The following is a description of a gene set: species: Mus musculus Mouse Gene Set: GOBP_REGULATION_OF_PROGRAMMED_CELL_DEATH Any process that modulates the frequency, rate or extent of programmed cell death, cell death resulting from activation of endogenous cellular processes., and this is the list of marker genes: Angpt1, Mertk, Wnt11, Mir20a, Myo18a, Serpinb9e, Nr1h4, Sptlc1, Tex11, Slc46a2, Hrk, Krit1, Ep400, Zeb2, Hells, Tnfaip8l2, Sox4, Zfp36 (NCBI Gene Id 22695), Dnajc5, Utp11, Prkdc, Pparg, Hdac2, Gsk3a, Slk, Cfdp1, Ccnd2, Thoc1, Brd8, Il2, Pla2g1b, Abraxas2, Comp, Ltk, Gcg, Mir25, Cdkn1b, Tbx3, Lyn, Csf2, Efhc1, Unc5c, Pdpk1, Zbp1, Id3, Hspb1, Folh1, Hdac3, Ptprc, Fis1, Mir92-1, Bcl2a1d (B cell leukemia/lymphoma 2 related protein A1d), Plk3, Mir293, Naa35, Adam17, Cdk11b, Lcn2, Prkch, Akt1, Plk1, Mir295, Pcgf2, Pcid2, Avp, Mad2l1, Sarm1, Epc1, Itch, Mrgbp, Selplg, Rrm2b, Dedd, Cdsn, Mir106a, Supv3l1 (NCBI Gene Id 338359), Ago4, Ltb, Sh3glb1, Lrp5, Tnfrsf12a, Ell3, Mir92-2, Adora1, Psme3, Ndnf, Pim2, Rad21, Eif2b5, Acaa2, Dhodh, Psmg2, Dad1, Bcl3, Son, Gbe1, Pdcd10, Hnrnpk, Rarg, Klhl20, Vnn1, Foxp1, Mdm4, Ppara, Ufm1, Nog, Xrcc2, Foxa1, Ccl12, Draxin, Prdx2, Smad3, Wnt4, Fgfr1, Traf1, Prkca, Zmat3, Tfap2a, Spry1, Mir294, Ube2z, Moap1, Hdac4, Hyou1, Tsc22d1, Nos3, Card14, Cdkn2d, Akt1s1, Pla2r1, Stat1, Epc2, Cxcl10 (NCBI Gene Id 15945), Dlc1, Mien1, Bace1, Ifnb1, Slc25a31, Ctsh, Nr3c1, Mtch1, Mtch2, Mtrnr2l7, Tnfaip8l3, Hsp90ab1, Rps6kb1, Map3k11, Ilk, Lgals1, Egln1, Pawr, Bid, Pip5kl1, Ctsd, Foxc2, Dll1, Grik5, Cbs, Itpr1, Phlda1, Tgfb1, Fosl1, Itga4, Bmpr1a, Hnf1b, Zbtb16, Styxl1, Pax2, Ctrb1, Gstp2, Tgm2, H2-M3, Icam1, Gas6, G6pdx, Tnfrsf1b, Fxn, Atf2, Rack1, Fnip1, Nkx2-6, Lypd3, Ambra1, Siglec1, Nck2, Pgr, Rnf31, Prkcd, Rybp, Prdx3, Cldn7, Gdnf, Nme5 (NME/NM23 family member 5), Snca, Grn, Mael, Diablo, Il2rb, Cdk4, Ier3ip1, Casp6, Pten, Kif14, Atm, Hsh2d, Igf2r, Vegfa, Ung, Cd44, Trim2, Slc1a1, Rhob, Csf1r, Dab2ip, Cpeb4, Oog1, Acsl5, Ddx42 (NCBI Gene Id 78522), Trp53, Nmnat1, Rapgef3, Cflar, Traf3, Plac8 (placenta-specific 8), Rps7, Pcdhgc4 (NCBI Gene Id 93707), Sh3rf1, Maged1, Ptgfr, Hsp90aa1, Casp14, Slc25a4, Kit, Syce3 (NCBI Gene Id 75459), Creb3l1, Sphk2, Adcy10, Zfp830, Grina, Prf1, Pla2g3, Ptprf, Itgav, Adam8, Ptma, Arf4, Hpgd, Degs1, Birc5, Il12a, Plk5, Serpinb9, Bbs10, Twist1, Bag1, Lep, Fyn, Trp53inp1, Cntf, Bdkrb2, Nes (nestin), Cd248, Tnf, Rxra, Phip, Sgk3, Hyal2, Atg5, Alkbh1, Daxx, Thap11, Msx2, Qrich1, Esr1, Foxe3, Ppp1r15a, Tlr3, Bbc3, Hmga2, Net1, Tnfaip3, Rock1, Tcim, Ikzf3, Edn1, Fabp1, Irak2, Nos2, Irf1, Mpv17l, Ghrl, Pcmt1, Rarb, Prok2, Eef1e1 (eukaryotic translation elongation factor 1 epsilon 1), Irak3, Abl1, Nfkbid, Tnfaip8l1, Fcer2a, Map3k5, Mybbp1a, Fbxo32, Nppc, Lox, Bnip3, Cd3g, Trim32, Fgf20, Mnt, Lcmt1, Yap1, Zfas1 (zinc finger, NFX1-type containing 1, antisense RNA 1), Atp6v0c, Nckap1l, Tctn3, Fzd1, Stxbp1, Sqstm1, Nol3, Slc2a3, Rnf157, Nqo2, Pidd1, Tox3, Caap1, Mllt11, Nrp1, Sp110, Rassf6 (NCBI Gene Id 73246), Pim3, Lzts2, Ptpa, Ar, Melk, Ccnd1, Siah1b (NCBI Gene Id 20438), Wwox, En2 (NCBI Gene Id 13799), Eif5a, Evi2b, Gata4, Pttg1ip (pituitary tumor-transforming 1 interacting protein), Gstp3, Bak1, Slc9a1, Cx3cr1, Actn4, Tcf7l2, Apip (NCBI Gene Id 56369), Stk17b, Npm1, Ang, Nqo1, Atg7, Bnip3l, Jak3, Bcl2l2, Map3k10, Slc27a4, Bcl2a1c, Akr1b1, Psmd10, Rpl26, Acvr1, Arg1, Wnt5a, Clip3, Kdm1a, Fgf10, Cblb, Hoxa13, Mmp9, Agap2, Srpk2, Dnajc3, Sod2, Hypk, Sox9, Sod1, Pycr1 (NCBI Gene Id 209027), Asic2, Prkd2 (protein kinase D2), Msx1, Mecom, Ywhaz, Nfix, Cdk19, Plaur, Psen1, Bad, Sfrp4, Cers6, Capn3, Map2k6, Irf8, Cyld, Gas1, Ager, Pth, Chek2, Snai2, St3gal1, Eef2k, Htr2b, Ccn1, Ankrd13c, Drd3, Dapk3 (death-associated protein kinase 3), Eif2a, Serpinb9d (NCBI Gene Id 20726), Traf6 (NCBI Gene Id 99098), Bmpr1b, Shh, Unc13b, Irf3, Scp2, Taf6, Tyro3, Ntf3, Zpr1, Cep63, C6, Stk3, Aldh1a1, Ghrh, Ripk2, Cd160, Stk26, Trpm7, Akap12, Ntrk2, Prmt2, Ace, Camk2a, Maz (NCBI Gene Id 17188), Rps3a1, Pou3f3, Oma1, Alms1 (NCBI Gene Id 381791), Cxcr2 (NCBI Gene Id 12765), Naa15, Parp1, Syngap1, Hpn, Smad5, Ube2m, Lig4, Klrk1, Naip5, Bdnf, Psen2, Insl3, Sncb, Aldh1a2, Actb (actin, beta), Map2k4, Uri1, Clu, Bmyc, Brca1, Ubd, Kcnh8, Ngb, Spdef, Fgfr2, Usp42, Sap18b, Noc2l, Eya2, Isl1, Gdf5, Mif, Fgf21, Sap18 (Sin3-associated polypeptide 18), Cd40lg, Wt1, Mir106b, Yeats4, Xiap, Cerkl, Tnfsf14, Cdkn2a, Taf9, Gli3, Nop53, Pramel1, Gsk3b, Tbx1, Rbm25 (NCBI Gene Id 70221), Igfbp3, Gstp1, Gstp-ps, Fam162a, Tmbim6, Stradb, Ltbr, Tnfrsf8, Tmem109, Dnm1l, Vhl, Golph3, Myocd, Aars1, Bcl6, Wdr35, Traf4, Ing1, Bhlhb9, Ppp1r13b, Il18 (interleukin 18), Pam16, Adcyap1 (adenylate cyclase activating polypeptide 1), Ccar2, Il20ra, Tnfrsf23, Creb3, Khdrbs1, Il6st, Pip, Cdk5, Malt1, Il19, Usp17le, Map2k5, Kras, Capn10, Adm (adrenomedullin), Nat8f1, Katnb1 (katanin p80 (WD40-containing) subunit B 1), Srpx (sushi-repeat-containing protein), Spp1, Hmgcr, Ccl19, Tomm70a, Sp100, Birc3, Zfp622, Tbx20, Gpx1, Slc35f6, Armc10, Prkcq, Fth1, Adprs, Pin1, Sycp2, Cradd, Dapk2, Map2k1, Oog3, Wnt16, Runx3, Mir19b-2, Acvr1c, Lifr, Apaf1, Hif1a, Map3k20, Carm1, Nlrc4, Cited2, Kitl, Gapdh, Phb1 (prohibitin 1), Rsl1d1, Id1 (NCBI Gene Id 98917), Gnaq, Notch1, Cat, P4hb, Nfatc3, Tfpt, Ywhah, Fndc1 (NCBI Gene Id 68807), Grid2, Ptpn2, Grem1, Gria4, Txnrd1, Rela, Bcl2l10, Hrg, Lrp6, Ppt1, Zbtb7a (zinc finger and BTB domain containing 7a), Traf7, Ubb, Klf4, Cxcr3, Ackr3, Foxc1, Ets1, Itgb1, Gsn, Blvra, Ahr, Ido1, Inca1, Card9, Madd, Bcl2l15, Ppp2r1a, Endog, Dock8, Arrb2, Mydgf, Ing2, Bcl2l13, Ccl21e (NCBI Gene Id 100504239), Knl1, Dicer1, Pmp22, Mapk9, Fga, Ppp5c, Fbxo10, Mtor, Tspo, Gadd45b, Pdx1, Ing4, Akt2, Mdk, Mutyh, Myb, Qki, Bard1, Plxnd1, Prop1, Fn1, Sphk1, Ptrh2, Erbb3, Aatf, Flt4, Sfpq, Hsp90b1, Lta, Babam2 (BRISC and BRCA1 A complex member 2), Traf2, Tmbim1, Nae1 (NCBI Gene Id 260355), Foxb1, Stat5b, Steap3, Rps3, Prr7, Ppargc1a (NCBI Gene Id 320239), Stub1, Dedd2 (NCBI Gene Id 67379), Syvn1, Ctns, Nox4 (NCBI Gene Id 50490), Fank1, Agtr1a, Myc, Tardbp, Higd2a, Slc39a10, Kank2, Tomm22, Park7, Ccng1, Ccl19-ps4, Atf6, Nr4a3, Trim35 (tripartite motif-containing 35), G2e3, Sik1, Dcun1d3, Flna, Rbm5, Spink2, Cx3cl1, Txndc12, Aifm2, Kat5, Usp15, Ptpmt1, Adrb1, Pou4f1, Fhl2, Lef1, Aimp2, Ccl19-ps6, Slc25a5, Shc1, Xpnpep1, Kdm2b, Ivns1abp, Hipk2, Eno1, Fbh1, Mapk8ip3 (mitogen-activated protein kinase 8 interacting protein 3), Fkbp8, Ptprz1, Rb1, Pde5a (phosphodiesterase 5A, cGMP-specific), Aurkb, Epcam, Apbb3, Mir124a-1, Hspb2, Prlr, Aipl1, Ankrd1, Thbs1, Vps54, Slc7a5, Por, Tnfsf4, Ormdl3, Dstyk, Bnip3l-ps, Gadd45a, Bmp2, Syk, Cblc, Igf1, Mir20b, D1Pas1, Crlf1, Sfrp1, Pdcd4, Gja1, Asah2, Fas, Ccar1, Trim39, Phlda2, Tgfbr1, Htra4, Hras, Pak2, Hk3, Bax, Itgb3, Krt18 (NCBI Gene Id 16668), G0s2, Gata2, Cck, Opn3, F2r, Wdr73, Cdc34 (NCBI Gene Id 216150), Cd27, Cd38, Hmgn5, Cd2ap, Usp17lc, Gramd4, Ntsr1, Stil (NCBI Gene Id 230631), Rgl2 (ral guanine nucleotide dissociation stimulator-like 2, NCBI Gene Id 19732), Naa38, Taf9b, Tfrc, Alx3, Sirt5, Birc7, Prodh, Dnaja3, Ucn, Nf1, Gimap8, Ncf2, Fbxo7, Atf4, Egln3, Npc1, Ddx20, Ptpn5, Ddrgk1, Ngf, Trrap, Sox8, Dpep1, Retreg1, Trap1, Cln3, Flcn, Rps6ka2, Adamts20, Mapk7, Il7, Foxq1, Trpv1, Fzd3, C1qbp, Usp36, Kcnj1, Ciapin1, Ppard, Pxt1, Map3k7, Cd59a, Tex261 (NCBI Gene Id 68003), Ing3, Nkx2-5, Gimap5, Clec7a, Ruvbl1, Epha7, Dipk2a, Ccn2, Mybl2, Lgmn, Nrbp2, Tmem161a, Tnfrsf18 (NCBI Gene Id 21936), Nr4a2, Fbxw7, Tnfsf11, Igf1r, Fbxo11, Ptpn1, C5ar1, Serpinb9f, Cidea, Braf, Agtr1b, Erbb4, Inhba, Ctnnbl1, Lrp1, Dlg5, Tfap4, Rnf34, Ednra, Casp2, Hcar2, Faim, Lhx3 (NCBI Gene Id 16871), Fnta, Proc, Thra, Mir17, Pcdhgc5, Niban2, Anxa1, Hhip, Ctsc, Nme2, Musk, Pdcd2, Skp2, Casp3, Ndufs3, Stat5a, Foxl2, Morf4l2 (NCBI Gene Id 71961), Slc7a11, Nlrp1a, Tpd52l1, Itsn1, Tent5b, Triap1, Tslp, Bcl2, Ncl, Efna1, Nfatc4, Htatip2, Eya4, Il10, Stx4a, Tomm40, Npy5r, Ednrb, Hspa9, Mcl1, Apoe, Hdgf, Raf1, Dmap1, Fgf2, Cdk5r1, Nupr1, Mbtd1, Agtr2, Slc40a1, Vdac2, Lrp2, Mir292, Dsg2, Trps1, Erp29, Smo, Mfn2, Itga5, Hspa5, Rbck1, Akr1c18, Gli2, Gata1, Dab2, Slc25a27, Trp73, Timp1, Serpinb13, Cyct, Hoxa5, Spry2, Ccl21f, Rps6ka3, Serpinb9c, Ptk2 (NCBI Gene Id 14083), Rapsn, Tmem215, Adam10, Star, Hsph1, Lmna, Cxcl1, Rgn, Rhoa, Mfsd8 (major facilitator superfamily domain containing 8), Tmbim4, Cideb, Tmigd1, Ccl21b, Bcl11b, Cul7, Kcnma1, Igbp1, Erfe, Map2k7, Cdc73, Laptm5, Prkaa1, Zfp385a, Dyrk3, Ankrd2, Hax1, S100b, Sirt4, Dusp6, Btg1, Gpam, Nrg1, Tnfrsf4, Ncoa1, Camk1d, Smad4, Bcl10, Cttn (NCBI Gene Id 68623), Pea15a, Bin1, Osm, Pax8, Egr3, Clec5a, Bhlhe23, Itm2c, Muc2, Cast, Egfr, Gnai2, Tle5 (TLE family member 5, transcriptional modulator), Sox2, Wnt10b, Ctnnb1, Tmem14a, Gnrh1, Ier3, Scx, Lims1, Zfand6, Tpt1, Stambp, Plk2, Hey2, Atox1, Prkaa2, Phlpp1, Txnip, Pramel7, P2rx7, Bclaf1, Sort1, Fgg, Tcf7, Actl6a, Pmaip1, Gapdhrt, Optn, Lhx4, Tifab, Ccl19-ps3, Rhbdd1, Mir93, Nod1, Gpld1, Mal, Tlr6, Gadd45g, Wnt1, Calhm2, Apbb1, Nat8b-ps, Med1, Qars1, Pla2g4a, Adipoq, E2f1, Hspb6, Dlx1, Tmem132a, Adrb2, Dpp9, Umodl1, Pepd, Pdgfrb, Crhr1, Frzb, Fadd, Asah1, Ngfr, Fgb, Angpt4, Muc4, B4galt1, Sgk1, Sra1, Pak3, Tgfbr3, Irs2, Hspa1b, Pin1rt1 (NCBI Gene Id 241593), Fgfr3, Lpar1 (lysophosphatidic acid receptor 1), Cd74, Ptk2b, Smarca4, Alpk2, Ankle2, Ctnna1, Rara, Dnaja1, Olfm1, Dkkl1, Kpna1, Map3k9, Birc2, Siah1a, Aif1, Plcg2, Il4, Ptgs2, Tfap2b (transcription factor AP-2 beta), Egln2, Cdkn1a, Phlda3, Nox1, Capn1, Nherf1, Pcp4, Serinc3, Tnfrsf1a, Tigar, Xrcc4, Hmgb2, Mlst8, Ube2b, Mtdh, Apc, Rnps1 (RNA binding protein with serine rich domain 1), Il1rn, Cdk1, Eif2ak2, Prkci, Nsmaf, Flt3l, Lims2, Prnp (prion protein), Nkx3-2, Muc1, Serbp1, Atad5, Hmox1, Grp, Rest, Neurl1a, Mt1, Adar, Sigmar1, Pnp, Naip6, Apbb2, Pdcd5, Plagl2 (NCBI Gene Id 99408), Itpkb, Gpx4, Pkhd1, Nuak2, Bok, Apex1 (apurinic/apyrimidinic endonuclease 1), Itga6, Mff, Snx6, Itga1, F2rl1, Slc39a7, Pdxk, Arg2, Mmp2, Araf, 4930453N24Rik, Msh2 (NCBI Gene Id 17685), Hgf, Pde1a, Il24, Rnf183, Jun, Ppp2r2b, Il7r, Scrib, Marchf7, Arhgap10, Dhrs2, Ccl5, Hnf1a, Mpz, Il12b, Card11, Opa1, Gch1, Tm7sf3, Fam72a, Bub1, Rps6, Arhgef7, Ift57, Six1 (NCBI Gene Id 20471), Aqp1, Ifit3b, Hipk3, Bcl2a1a, Cidec (NCBI Gene Id 14311), Chst11, Cdc34b (NCBI Gene Id 53980), Mycn, Bag6, Rps6-ps4, Bmp4, Pa2g4, Smpd1, Tjp1, Arl6ip1, Srsf6, Rnf122, Epo, Esr2, Spata2, Gcm2, Deptor, Ascl1, Nat8f7, Ecscr, Pdcd6, Htra1, Sema5a, Tia1, Hmgb1, Trip10, St8sia2, Ep300, Pou3f4, Trp53bp2 (NCBI Gene Id 98424), Zc3h12a, Nup62, Notch2, Dkk1, Vdac1, Dynapl1, Epha4, Rad9a, Sirt1, Wfs1, Lgals2, Tgfb3, Cdc42, Rybp-ps, Bcl2l1, Arnt2, Cabin1, Bag3, Ddias, Tmc8, Gimap3, Sin3a, Bag4, Cd274, Rb1cc1, Ihh, Dpp8, Lats1, Casp9, Ttpa, Pdia3, Prkcg, Ifit2, Cryaa, Gsdma3, Acin1, Smg9, Cyp1b1, Rbfox2, Kifap3, Rbm10 (RNA binding motif protein 10), Eef1a2, Btc, Il3, Pias1, Jak2, Cd59b, Sh3rf2, Fate1, Dspp, Csnk2a1, Col18a1, Itgb3bp (NCBI Gene Id 67733), Clcf1, Mpl, Zswim2, Tgfa, Casp12, Ints1, Mag, Cav1, Capn2, Sfrp2, Abl2, Grk2, Nos1, Glo1, Csrnp3, Mdga2 (NCBI Gene Id 320772), Ret, Palb2 (NCBI Gene Id 233826), Pomc, Stk4, Rasa1 (NCBI Gene Id 218397), Gba1, Mt3, Six4, Zfp36l1, Pdcd5-ps, Fasl, Ltf, Anp32a, Ccr5 (C-C motif chemokine receptor 5), Gfer, Hand2, Nacc2, Ramp2, Yme1l1, Eno1b, Fgf4, Rapgef2, Bik, Hk1, Ano6, Bcl2a1b, Cd40, Emilin2, Nf2, Ern1, Frs2 (fibroblast growth factor receptor substrate 2), Ldha, Ndufaf4, Emilin1 (elastin microfibril interfacer 1), Cacna1a, Siah2 (NCBI Gene Id 99497), Map4k4, Mrtfa, Cdh5, Htra2, Usp17la, Naip2, Bnc2, Plscr3, Usp47, Rnf7, Cryba1, Tgfb2, Angptl4, Ei24, Aifm1, Prap1, Mgmt, Bmf, Zc3h8, Mir18b, Gnai3, Eya1, Serpinb9g, Rictor, Aamdc, Eng, Wnt9a, Rrn3, Ppp1ca, Vdr, Anp32-ps, Lck, Hip1, Ccl19-ps5, Creb1, Rorc, Pik3cg, Mir290a, Prokr1, Aven, Atp7a, Snai1, Rpl10-ps3, Lonrf2 (NCBI Gene Id 98460), Nod2, Lats2, Akr1a1, Erbb2, Ruvbl2, Ercc3, Ank2, Nsmf, Il13, Set, Slit2, Map3k12, Pafah2, Tfap2d, Met, Tmem164, Casp7, Tek, Nfe2l2, Mical1, Apoh, Mapk8, Oog2, Fcer1g, Cited1, Fap, Usp27x, Ccr7, Nck1, Tnfsf12, Ntrk3, Sav1, Foxo1, Vip, Ppif, Fmr1, Fcmr, Xbp1, Selenos (selenoprotein S), Socs1, Vegfb, Hsf1, Alx4, Hdac1, Prdm11, Casp8, Smpd2, Trp63 (transformation related protein 63), Rln1, Mtnr1b, Anp32b, Pycard, Faiml (Fas apoptotic inhibitory molecule like), Herpud1, Ccnl2, Faf1, Grin1, Ddr2 (discoidin domain receptor family, member 2), Actc1, Atoh1, Agt, Osr1, Cib1, Rtkn2, Ckmt1, Cd47, Acer2, Pik3ca, Nell1, Itprip, S100a8, Mapk8ip2, Cftr, Meis3, Tle1, Htt, Ppp2r1b, Ghitm, Arrb1, Ybx3, Adamtsl4, Pax4, Gper1, Bmi1, S100a9, Ahi1, Tnfrsf10b, Tnfsf10, Bmp7, Cxcr4, Neurod1, Tmem196, Eif2s1, Stpg1, Tlr4, Camk2d, Grk5, Grm7, Usp17lb, Chl1 (NCBI Gene Id 12661), Dynap, Atf5 (activating transcription factor 5), Mdm2, Tsc22d3, Casp1, Parl, Gls2, Usp7, Hs1bp3, Mapkap1, Grk1, Pak4, Zdhhc17, Pcnt, Pim1, Rffl, Pcsk9, Meaf6, Agrn (agrin), Gclm, Pak5, Nfkb1, Ptcra, Acot1, Rtkn, Pias4, Map3k1, Pou4f2, Serpine1, Ncoa3, Gzma, Cebpb, Nefl, Aldh1a3, Plcg1, Perp, Gata3, Fmn2, Fstl1, Ubqln1, Prr5, Higd1a (HIG1 domain family, member 1A), Pdcd7, Vstm2l, Rpl10, Hcls1, Lamtor5, Prdm9 (NCBI Gene Id 213389), Ffar4, Sirt2, Fcgr2b, Pik3r1, Grin2a, Usp17ld (ubiquitin specific peptidase 17-like D), Wnk3, Ifit3, Faim2, Pik3cb, Brms1, Chd8, Pdk4, Bag5 (NCBI Gene Id 74791), Anxa5, Arl6ip5, Oxr1, Dusp1, Alox12, Kdr, Htr2a, Rrp1b, Khdc3, Zmynd11, Ntf5, Ccnl1, Aldh2, Pitx3, Tradd, Mitf, Inpp5d, Mnat1, St6gal1, Ccl21a, Zfp346 (NCBI Gene Id 26919), Ing5, Ddx19a, Sdf2l1, Tnfaip8, Inhbb, Lrrk2, Ccl3, Sema3e, Mapk8ip1, Scg2, Fzd9, Rnf144b, Gata6 (GATA binding protein 6), Asns, Cbl, Amigo2, Mre11a, Camk2b, Ddit3 (NCBI Gene Id 13198), Men1, Kcnip3, Pink1, Ripk3, Egr1, Phb2, Gfral, Klf11, Mir363, Muc20, Kcnb1, Prkce (NCBI Gene Id 98094), Vps72, Hip1r, Cln8, Pik3cd, Fignl1, Traf5, Oga, Blm, Cxcl12, Eya3, Ercc5, Rps6ka1, Nanos3, Adora2a, Ptn, Peli3, Acer3, Ptms, Tnfsf15, Trem2, Prelid1, Birc6, Cntfr, Prkra, Ccl21d, Dbh, Tnip2, Hspd1, Cryab, Tax1bp1, Ccl19-ps1, Pdpn, E2f3, Abcc9, Ada, Axl, Atp2a2, Dapk1 (NCBI Gene Id 76556), Casp4 (NCBI Gene Id 12363), Tert, Gpi1, Maea (NCBI Gene Id 80495), Skil, Vtcn1, Rag1, Mir19b-1, Anp32e, Tmf1, Rassf2, Mst1, Ddx3x (DEAD box helicase 3, X-linked), Ucp2, Wnt7a, Ifng, Sc5d, Trem1, Gapdhrt2, Glp1r, Nr4a1, Ikbkg, Bcap31, Mef2c, Serpinb9b, Il27ra, Unc5b, Pdcd1, Ppia (peptidylprolyl isomerase A), Card10, Plekhn1, Arel1, Barhl1, G6pd2, Nr2e1, Epor, Col2a1, Tnfrsf22, Pde3a, Septin4, Foxo3, Cd24a, Jmy, Bfar, Ogg1, Il6, Serpinb9h, Kdm2a, Src, Prkn, Spop, Ufl1, Dffa, En1, Wrn, Grik2, Trim24, Smad6, Insl6, Scin, Kdm6a, Rxfp2, Sycp2l, Ppid, Ube2v2 (NCBI Gene Id 98028), Ppef2, Mir18 (NCBI Gene Id 387135), Fto, Rgcc, Uaca, Gclc, Gal, Top2a, Adnp, Ripk1, Sox10, Lrp8, Naa16, Ppp1r10 (NCBI Gene Id 66450), Atad3a, Osgin1, Serpinb2, Fgf8, Sct, Stk40, Zfp819, Eif2ak3, Btg2, Bcl2l11, Nnt, Mecp2, Ntrk1, Api5, Bcl2l14, Ect2, Cops5, App, Pcdhgc3, Ndufa13, Atf3, Irf5, Ncam1, Hck, Twist2, Il1b, Hspa8, Becn1 (beclin 1, autophagy related), Pml, Coro1a, Prdx5, Ip6k2, Rnu12, Aurka, Cnr1, Sell, Peli1, Ctla4, Nono, Ptgis, Nuggc, Prkcz, Plscr1, Ddb1, Ghsr, Bcl2l12, Cth, Dnmt1, Nkx3-1, Lgals3, Fem1b, Gsdme, Naip1, Morf4l1